The following is a description of a gene set: part of: Defects of Coagulation cascade Reactome Pathway: Aggregated β-amyloid interacts with fibrinogen studied in species Homo sapiens Fibrinogen and fibrin, proteins typically confined to the bloodstream, can accumulate in the brain's extravascular space due to blood-brain barrier disruptions associated with various neurological conditions. In the brain, fibrinogen or fibrin can co-aggregate with amyloid beta (Aβ) peptides (APP(672-711), APP(672-713)) - a hallmark of Alzheimer's disease - potentially leading to the formation of abnormal blood clots that are more resistant to fibrinolysis. This process may contribute to the vascular pathology observed in Alzheimer's disease patients.<br><br>., and this is the list of marker genes: FGB, FGA, FGG, APP